Given this list of marker genes TP53INP1, SYTL1, BTNL9 (NCBI Gene Id 153579), HLA-DQB1 (NCBI Gene Id 7924), ITGAM, IL4R, GLIPR1, MYO1G, PDE4B, ABAT, IKBKB, YPEL2, PLAAT4, CD37, STK17B, LGALS9, KLF6, RCBTB2, IL13RA1, F11R, GRM7, HLA-DQA1, SATB1, TXNIP, ANXA4, KLK1, RGS1, CD27, RTF2, TMEM156, PYHIN1, YPEL5, UBR5-DT, FCRL4, SAT1, CX3CR1, HSD11B1-AS1, PLCXD2, LCP2, PTGS1, AK1, NRCAM, TSC22D3, PTAFR, ZBP1, ID2, UCP2, NEAT1, TENT5C, SCARA5, LYZ, SLC2A3, FCMR, CD69, FUT6, SYT17, CREBRF, SORBS2, TRIM22 (NCBI Gene Id 10346), HLA-DOB, LMO2, ZBED2, JUN, IGHA1, POLD4, IDS, UBE2H, TNFRSF14, MPEG1, DAPK2, CD44, ZNF91, MR1, C1RL, ALDH2, LLGL2 (NCBI Gene Id 3993), APCDD1 (APC down-regulated 1), GSDMB, CD72, MXD4, ZNF594 (NCBI Gene Id 84622), ALOX5, ZMAT3, here is a description of the gene set: from publication O'Donnell KA, Yu D, Zeller KI, Kim JW, Racke F, Thomas-Tikhonenko A, Dang CV (PMID 16508012) Genes down-regulated in P493-6 cells (B lymphocyte, Burkitt's lymphoma model) by MYC and up-regulated by RNAi knockdown of TFRC. species: Homo sapiens Overexpression of transferrin receptor 1 (TFRC1), a major mediator of iron uptake in mammalian cells, is a common feature of human malignancies. Therapeutic strategies designed to interfere with tumor iron metabolism have targeted TFRC1. The c-Myc oncogenic transcription factor stimulates proliferation and growth by activating thousands of target genes. Here we demonstrate that TFRC1 is a critical downstream target of c-Myc. Using in vitro and in vivo models of B-cell lymphoma, we show that TFRC1 expression is activated by c-Myc. Chromatin immunoprecipitation experiments reveal that c-Myc directly binds a conserved region of TFRC1. In light of these findings, we sought to determine whether TFRC1 is required for c-Myc-mediated cellular proliferation and cell size control. TFRC1 inhibition decreases cellular proliferation and results in G1 arrest without affecting cell size. Consistent with these findings, expression profiling reveals that TFRC1 depletion alters expression of genes that regulate the cell cycle. Furthermore, enforced TFRC1 expression confers a growth advantage to cells and significantly enhances the rate of c-Myc-mediated tumor formation in vivo. These findings provide a molecular basis for increased TFRC1 expression in human tumors, illuminate the role of TFRC1 in the c-Myc target gene network, and support strategies that target TFRC1 for cancer therapy. Human Gene Set: ODONNELL_TARGETS_OF_MYC_AND_TFRC_UP